The following is a description of a gene set: studied in species Mus musculus Mouse Gene Set: GOBP_WOUND_HEALING_SPREADING_OF_EPIDERMAL_CELLS The migration of an epidermal cell along or through a wound gap that contributes to the reestablishment of a continuous epidermis., and this is the list of marker genes: Hbegf, Clasp1, Fermt1, Itga5, Arhgap24, Wnt7a, Phldb2, Itgav, Msx2, Scnn1b, Plet1, Mmp12, Col5a1, Acvrl1, Scnn1g, Pten, Clasp2, Lrg1, Rreb1, Mtor, Fermt2, Ajuba, Itgb5